The following is a description of a gene set: studied in species Homo sapiens Human Gene Set: CHOP_01 Genes having at least one occurrence of the motif NNRTGCAATMCCC in the regions spanning 4 kb centered on their transcription starting sites. This matches the DDIT3, CEBPA DIFF GENES transcription factor binding site V$CHOP_01 (v7.4 TRANSFAC)., and this is the list of marker genes: PCDH18, EIF4A1, ZNF532, GLRA2, FAR2, CYP7A1, NUAK1, ADSS2, JMJD1C, MOAP1, CARS1, PCDH17, ZBTB37, TBL1X, LURAP1L, TNPO3, NSD3, SLC6A2, IMMT, GGN, NPAS3, PPARGC1A, ARHGEF6, IL23A, MAML3, HOXA5, STMN1, ZHX2, CTNND1, SLC16A11, PDZD4, HOXA13, TRERF1, CEBPB, RNF121, SOX4, LASP1, CACNA1E, RHBDL3, CDK6, S100A9, KCTD15, TFAP2D, SLC35A5, KLF12 (KLF transcription factor 12), FGF21, ETF1, ROGDI, SH3GLB2, HMGB1, SLITRK3, FBXO11, PHF21A, RIMS1, RNF19A, SARS1, EXOSC6, TRIB1, PPL, FGF14, PTCD2, INPP4A, PCDH9, NPAT, JAKMIP2, CDK14, FST, TM6SF1, HJV, SLC12A5, NKX2-1, PDZRN4, GPHN, PRDM1, TNFSF10, STAC, SESN2, ADM, HOXC5, BPTF, PLXNC1, KITLG, HMGB2, CD247, IGSF9B, KDM3B, CACNB2, RNF43, PPP2R2A, NFE2L2, LMO4, NTRK2, TMEM164, FUT11, CDK5 (NCBI Gene Id 1020), GLUD1, SRSF2, ATF3, RHOJ, MEF2C, ZBTB10, CNTN6, ZBTB11, GNB3, KLF3, ITGB3BP, ZNF362, MCC, NDUFA4L2, ITGA3, CYP51A1 (cytochrome P450 family 51 subfamily A member 1), ITGB1BP2, B3GALNT1, MAP4, MAP2K6, GCG, GPR27, HOXB7, BORCS7 (BLOC-1 related complex subunit 7), PLEKHA6, PRR11, NIBAN1, SMOC2, SLC38A2, GLRX5, USP9X, PHOX2B, EVX1, HERPUD1, HHEX, SHLD2, ATM, SPATC1, ITPR1, PID1, PHF6, MOSPD1, PTCH1, SERBP1, NTRK3 (neurotrophic receptor tyrosine kinase 3), SRPK2, PER1, AP2A1, SIAH3, HOXA11, LRRTM4, WWP2, TYRO3, SFRP2 (NCBI Gene Id 6423), AHCYL2, MIDEAS, AHNAK, COL6A3, IRS4, ANKRD28, TMEM178A, OTUD4, PLXND1, SUPT16H, ACTC1, SEMA5B, H1-4, NDC1, TFAP2B, SYNCRIP, BHLHE40, SNCAIP, WIPF1, ID2, SLC35D1, MEIS1, KCNN2, BCL2L11, HTN1, DYRK1B, IARS1, PCDH7 (protocadherin 7), TPI1P2, HMGN2, STC1, UVRAG, HTR2C, MYL1, YBX3, KMT2D, TPPP3, RTP1, TOB1, HMOX2, OTOS, ATXN7L2, LRATD2, TBCC, SOCS5, CBX8, SLC4A2, LCOR, CASK, ABLIM1, SHKBP1, GABRA1, SERPINF1, TFAP4, RAI1, SGIP1, VEGFA, SKA2, DPYSL2, CNTFR, GARS1, TTN, TAC4, RUNX1T1, ISL1, FGF11, VDR, PIP4K2B, CAST, NFKBIA, RAB3IP, KLF3-AS1, SESN3, LRP2, H2BC5, LMO3, CREBZF, BCL11A, MBNL1, PTBP3, EIF4A2, FSBP, DSEL (NCBI Gene Id 92126), HOXB9, RNF220, GGNBP2, STK40, C3orf36, PCYT2, DACH1